The following is a description of a gene set: Genes having at least one occurence of the motif GAGCCAG in their 3' untranslated region. The motif represents putative target (that is, seed match) of human mature miRNA hsa-miR-149 (v7.1 miRBase). species: Homo sapiens Human Gene Set: GAGCCAG_MIR149, and this is the list of marker genes: KCNK5, DLG4, CCDC6, SLCO3A1, PLAG1, ACLY, FRMD4A, MYCL, ATP2A2, EXOC5 (exocyst complex component 5), CASP2, SRSF5, ADD1, CD47, TMEM245, CCT3, LONRF1, TNFRSF19 (NCBI Gene Id 55504), ARHGEF5, ACVR1B, VLDLR, APPL2, BCL2L2, RNF2, PHLDB1, TRIM55, PURB (purine rich element binding protein B), CCNI, PLPP3, DCLRE1B, PKDCC, MCAT, ESYT3, CD72, APOB, NF2, EDA, CTCF, ADGRB1, FOSL1, PHLPP2, TEX261, DNAJB12, PHC1, CREBL2, ID4, TOP1, RAP1B, CLCN6, KHSRP, LMBR1L, RSBN1L, BAIAP2, HNRNPA1, EPHB3, LHX6, TFAP4, B3GAT1, SMYD5, FCHSD1, ZNF335, NTRK3, PDGFRA, OXSR1, LRCH4, ZMAT4, BRD10, SNCB, PCDH19, SEMA4G, LSM12, PPM1F, SH3PXD2A, KLHL3, PRPS2, SP1, NAV2, MYO18B, EXT1 (exostosin glycosyltransferase 1), SEC24C, SF1 (splicing factor 1), RIMS4, SLC11A2, CDK17, ARPC4, CYB5B, MPZ, TBC1D22B, NCDN, TLCD3B (TLC domain containing 3B), SRC, SHROOM2, SLC6A8, NDST1, POLR3H, IGSF9B, UBTD2, UBAP2, CEP95, CD59, AFF2, AMOTL2, CBX1, MIB1, ICA1, USP10, IGF2BP1, IGFBP5, HERC2P9, RAB3D, LPCAT4, DUSP16, CRTC2, BRPF3, MARCKSL1, COL4A3, NFIB, HS6ST2, IQSEC2, ARID1A, RAP1A, ZBTB2, GIT1, CLCF1, PAK3, YWHAZ, BHLHE22, MLEC, FBXL16, CHKB, TMEM50B, MPI, ACACA, PIP4K2B, TCF12, DLL1, BTG2, LUC7L3, VCF1, RPS6KB2, TNXB, KAT7, CCDC88B, SERF2, PLEKHA6, JADE2